Given this list of marker genes ABLIM1, ZNF324, RRP12, FOXN3, EIF3K, KIT, WFS1, EEIG1, NET1, RNF130, FBP1, TULP1, CSGALNACT1, EHD3, CCNG1, PLA2G15, KCNIP2, ANXA9, RFX1, CD247, DBNDD1, PRDM16, SGSM3, CERK, ZDHHC11, KLRB1, C2orf68, RPL18, IGFLR1, FBL, RPL11, SCTR, ATXN7L3B, SYNJ2, CBLC, MEGF6, DCAF10 (NCBI Gene Id 80211), AK5 (NCBI Gene Id 26289), ZCCHC24, SESN1, POLR1E, FRAT1, DOT1L, CAMK2G, TAF7L, VSIG10, RPH3AL, PAGR1, SLC35C2, SYPL1, ITPKB, VEGFB, PIK3R1, ERGIC3, RNF24, TTC9, EIF3H, CEACAM21, SPTSSA, COL10A1, RSL1D1, AKR1B1, CUX1, RPS3, TCF20, PIGQ, EIF3D, ZNF212, TGM2, MLLT1, ZMAT3, MACROD1, MAML3, GPX5, EIF3E, INCENP, GPX4, EEF1B2, DNAH17, SEMA4C, APOBR, ZBTB18, EVI2B, POMZP3, CDC14A, BLTP2, BTG1, ARF4, SYTL2, SLC4A10, ITM2C, NOSIP, AP1S2, EIF3L, FBXW4P1, HOPX, CAD, TSFM, IGF2R, CLEC3B, RPL10A, NT5E, RAB40C, MSL2, IRS4, TPPP3, ABCB1, PLXDC1, MAP2K6, BMPR1B, MYO6, EIF3F, PDZD2, ZFP37, P2RX4, SEC61A1, PPM1F, ALOXE3, RGCC, UXT, HSPA1A, AKR1A1, POU3F3, SSBP2, GATA3, ZNF395, LIN7B, GK2, FKRP, LIAS, EFNA4, CCT8L2, MYG1, RBMX (NCBI Gene Id 8258), RPS5, RERE, PACSIN2, ARRB1, NRDE2, NAALADL1, RPL6, ARFGAP2, ITFG2, BACH2, SLC16A10, PRM2 (NCBI Gene Id 5620), DHPS, P4HTM (NCBI Gene Id 54681), CTSW, BSCL2, FAH, CD37, SLC41A3, GPR183, SLC43A1 (NCBI Gene Id 8501), PTGES3 (prostaglandin E synthase 3), ZNF671, RIC8B, LINC00623, TOR1AIP1, MED9, IRS2, ABCA3, PFDN5, SERGEF, RPS17P5, NRTN, C11orf21, NCF1C, BAG3, CTSF, CCR2, NRAP, RGL2, AGBL5, TACSTD2, ANGEL1, SLC27A5, ST13, IL11RA, PLK3, FGF9, CRLF1, GSS, RNASEL, SORCS3, NMUR1, ID3 (inhibitor of DNA binding 3), EVI2A, SSR2, ANXA1, VPS51, NDRG2, HADHA, ADARB1, PAWR, DPEP2, here is a description of the gene set: species: Homo sapiens from publication Hutcheson J, Scatizzi JC, Siddiqui AM, Haines GK 3rd, Wu T, Li QZ, Davis LS, Mohan C, Perlman H (PMID 18275831) Genes up-regulated in comparison of healthy CD4 T cells versus systemic lupus erythematosus CD4 T cells. Gene expression profile studies have identified an interferon signature in whole blood or mononuclear cell samples from patients with systemic lupus erythematosus. This study was designed to determine whether specific lymphocyte and myeloid subsets freshly isolated from the blood of systemic lupus erythematosus patients demonstrated unique gene expression profiles compared to subsets isolated from healthy controls. Human Gene Set: GSE10325_CD4_TCELL_VS_LUPUS_CD4_TCELL_UP